The following is a description of a gene set: Human Gene Set: GSE26290_CTRL_VS_AKT_INHIBITOR_TREATED_ANTI_CD3_AND_IL2_STIM_CD8_TCELL_DN from publication Macintyre AN, Finlay D, Preston G, Sinclair LV, Waugh CM, Tamas P, Feijoo C, Okkenhaug K, Cantrell DA (PMID 21295499) Genes down-regulated in cytotoxic T cells: control versus treated with Akt inhibitor VIII. In cytotoxic T cells (CTL), Protein Kinase B /Akt is activated by the T cell antigen receptor (TCR) and the cytokine Interleukin 2 (IL2), in part by phosophorylation of Akt by Phospholipid dependent kinase 1 (PDK1). The role of PDK1 and Akt in CTL has however not been fully defined. In order to explore the relative roles of these kinases in CTL we used microarrays to profile the gene expression of control and PDK1 null CTL. In separate experiments we compared the gene expression profiles of control and Akt inhibitor treated CTL. species: Homo sapiens, and this is the list of marker genes: SPTY2D1, KRT7, HEG1, RAB8B, LEPR, TCEAL8, GPAT3, FBXO32, ARHGAP17, ITPRIP, PLPP1, CDRT4, CBR3, ESYT2, CAMK2G, TP53RK, IFNAR2, RCBTB2, TRAFD1, CHSY1, DUSP14, PDCD10, HMGCS1, HVCN1, CAPG, ACVR2A, MORC3, CASP4, MOV10, GDPD5, TBL1X, NRROS, CD40LG, SDCBP, SECTM1, ZAR1 (zygote arrest 1), DOCK9, EGFL6, PLEKHG3, PLXNA4, JAML, KPNA5, LST1, CLPB, FES, GPR155, BCL2A1, SEMA4C, CORO2A, L3MBTL3, ETV3, MICAL1, ASGR1, LRRN3, LMNA, CD48, DIP2B, TNFAIP8, LANCL1, CROCC, NECAP2, SNTB1, SGTB, GAS2L1, CRLF3, MAP3K8, CSGALNACT2, GIMAP1, HMGCR, ZBTB39 (NCBI Gene Id 9880), MBP, ITPR1, TNFSF11, SCAI (NCBI Gene Id 286205), RAB9A, ARHGEF6, TLK1, ELOC, RGL4, LAIR1, FXYD7, ZFP28, PTPRN2, FDPS, P2RX4, IRF2BPL, ZNF575, IL4R, DPY30 (dpy-30 histone methyltransferase complex regulatory subunit), CMTM3, IL17RB, ADARB1 (NCBI Gene Id 104), SLC41A1 (NCBI Gene Id 254428), TRPM2, SAMSN1, LY9, UBASH3B, CD1A, MARCKSL1, MYO1E, GBP5, DUSP10, OSM, RAP2B, PPFIBP1, SERTAD2, RPS6KA5, RELL1, S100A4, RAB24, MOB1B, CD9 (CD9 molecule), ARL6, STK40, DNMT3B (NCBI Gene Id 1789), AKR1A1, RIT1, NIPAL3, JADE2 (jade family PHD finger 2), GPN3, CNIH4, PDE4D, PLAU, COPS4 (NCBI Gene Id 95620), GOLGA7B, RPTOR, DGKD, SOCS1, GNPDA1, IGSF9B, TP53BP1, CD82, RNF144A, PWWP2B, FOXN3, HOPX (NCBI Gene Id 84525), ASIC1, FAM241B, ST3GAL5, TGFBR1, SIGLEC17P, PSMB9, PAG1, IRF4 (NCBI Gene Id 4592), GSTA4, EFHC2, FRMD4B, BIRC3, SELENOK, BCL9, WIPI1, JARID2, IMPACT, CLSTN1, TGDS, XRN1, SP4 (NCBI Gene Id 6671), OSTC, JUND, CD72, PHYH, HAVCR2, SPIN1, NEK6, LIF, RNF216, SV2A, MSMO1 (NCBI Gene Id 6307), CSTF1, SYNE3, TAB3, MAN1C1 (mannosidase alpha class 1C member 1), CLEC16A (C-type lectin domain containing 16A), TAGAP, DNAJB2, IL21, PRKCA, AMIGO2, LACTB, CALCOCO2, PTGIS, ARRB1, NPTX1, MAML3, C1orf162, TANC2, GNG2, PLAUR, NAB2, MPZL3, NDFIP2, IL18, TAP1, HPS4, PSTPIP2, RHOC, NCOA3